Given this list of marker genes LBH, RUBCNL, SPATA2, WIPF2, RBMS1, PPM1B (protein phosphatase, Mg2+/Mn2+ dependent 1B), YRDC, RUFY3, DSC3, KDM4B, EPOR, CREB3L2, ELOA, TRIM24, CBFA2T3, PTP4A3, ZNF512B, PISD (NCBI Gene Id 29838), MXD1, GNS, ARHGAP32, FKBP1A, CALU, KCNN1, ABHD3, KPNA2, SSH1, here is a description of the gene set: Human Gene Set: HOLLEMAN_VINCRISTINE_RESISTANCE_ALL_UP species: Homo sapiens Childhood acute lymphoblastic leukemia (ALL) is curable with chemotherapy in approximately 80 percent of patients. However, the cause of treatment failure in the remaining 20 percent of patients is largely unknown. from publication Holleman A, Cheok MH, den Boer ML, Yang W, Veerman AJ, Kazemier KM, Pei D, Cheng C, Pui CH, Relling MV, Janka-Schaub GE, Pieters R, Evans WE (PMID 15295046) Genes distinguishing vincristine resistant and sensitive ALL (B- and T-lineage ALL); here - genes up-regulated in the drug resistant samples.